Given this list of marker genes SKIC3, GALT, SLC2A2 (NCBI Gene Id 6514), GALE, GALK1, SLC25A13, GALM, here is a description of the gene set: Hypergalactosemia studied in species Homo sapiens Human Gene Set: HP_HYPERGALACTOSEMIA Elevated concentration of galactose in the blood.